The following is a description of a gene set: Human Gene Set: HP_BRACHYTURRICEPHALY Brachyturricephaly Abnormal vertical height of the skull and a shortening of its anterior-posterior length, frequently combined with malformations of the occipital region. studied in species Homo sapiens, and this is the list of marker genes: SYT1, FHL1, RECQL4, FAM20C, SP7, FGFR1, SKI, FGFR2, PEX1